The following is a description of a gene set: studied in species Mus musculus Mouse Gene Set: MSGN1_TARGET_GENES from publication Yevshin I, Sharipov R, Kolmykov S, Kondrakhin Y, Kolpakov F (PMID 30445619) Genes containing one or more binding sites for (Msgn1) in their promoter regions (TSS -1000,+100 bp) as identified by GTRD version 20.06 ChIP-seq harmonization., and this is the list of marker genes: Haus3, Epb41l5, Mir3073a, Tbxa2r, Ptgds, Dlg3, Gm15461, D430040D24Rik, Acot11, Mir30d, Gm18303, Pcm1, Nin, Spink4, Flrt3, Cmtr1, Grin2c, Mycn, Fabp7, Pip4k2a, Sh3bp1, Cc2d2a, Mms19, Hoxb3, Borcs5, Pwwp2a, Prss22, Dusp1, Gpt2, Lefty1, Trp53bp1, Gm24432, Rasgrp3, Zbtb18, Arg1, Cacna1s, 2010310C07Rik, Cmip, Dgkz, Gm12301, Pcbp4, Mrpl3, Aanat (NCBI Gene Id 11298), Mir7687, Spart, Ptprz1, Ppm1k, Prickle1, Gpr19, Cyp4x1, Dnajb13, Anks1, Ropn1l, Gm14050, Rbm4, Ehf, Poln, Robo3 (roundabout guidance receptor 3), 1700016A09Rik, Taf11, Atp8a1, Lypla2, Limch1, Ap2b1, Mir3073b, Adamtsl2, Ppp3ca (protein phosphatase 3, catalytic subunit, alpha isoform), Kcnh7, Dll3, Fgd4, Rftn1, Pex12, Lats2, Hmgxb3, 4933417E11Rik, Gm4117, Rimbp2